Given this list of marker genes MAPK8, ACTA1, LIMK2 (NCBI Gene Id 3985), SLC9A1, CCN1, ROCK1, PPP1R12A, JUN, LIMK1, SLC9A3, RDX, ROCK2, DIAPH1, ATF2, VCL, PRKCZ, SH3GL2, PARD6A, MRTFA, CDKN1B, MSN, PIP5K1C, CDC42, TLN1, SCAI, EZR, PIP5K1A, PIP5K1B, PLD1, MYL2, FOS, CIT (NCBI Gene Id 11113), MAPK12, PLD2, ITGB1, PTEN, CFL1, PKN2, SRF, PKN1, RHOA, MAP2K6, F2RL2, MAP2K4 (mitogen-activated protein kinase kinase 4), MAP2K3, here is a description of the gene set: species: Homo sapiens Human Gene Set: PID_RHOA_PATHWAY from publication Schaefer CF, Anthony K, Krupa S, Buchoff J, Day M, Hannay T, Buetow KH (PMID 18832364) RhoA signaling pathway